Given this list of marker genes Emp2, F2r, Corin, Stc1, Gja1, Or51e2, Adora1, Adipoq, Cyba, Kcnn4, Nherf1, Inpp5k, Ptger3 (NCBI Gene Id 19218), Coro2b, Edn1, Gja5, Uts2, Gas6, F2rl1, Pdgfb (NCBI Gene Id 18591), Spx, Ttr, Uts2r, Drd2, Ptpro, here is a description of the gene set: Mouse Gene Set: GOBP_REGULATION_OF_RENAL_SYSTEM_PROCESS Any process that modulates the frequency, rate or extent of a system process, a multicellular organismal process carried out by the renal system. species: Mus musculus